Given this list of marker genes PRDM1, FOXP1, HDAC4, GALNT18, LSM8, OLFM1, ANKS1B, NDNF, HSP90B1, SH2B3, SP3, DDIT4 (DNA damage inducible transcript 4), FEZ2, MPZ, FOXO3, CYTIP, ANAPC10, DBT (NCBI Gene Id 1629), HMGCS1, FBXW7, PDS5B, KAT6A, TSPAN7, RERG, PTBP2, SLC37A3, FBXO8, SACS, FAM13C, RHOB, ACTA1, WDR43, LELP1, PAX6, LAMB1, HARBI1, ZNF772, SLC35G2, ADGRB3, GMFB, RBPJ, G3BP1, GRIK1, CDH12, PRKCE, TMEM143, CBX5, SANBR, STAM, INPP4A, HOOK1, USP40, SNX6, WBP1L, SOD2, NFIB, CDK17, RAB8B, NFIA, ANKRD40, USP42, ARMCX1, SDC2, MAEL, BRMS1L, RBSN, CRIM1, UBR5, PARP1, ELK4, ACSL3 (acyl-CoA synthetase long chain family member 3), RCN2, C18orf54, DENND5B, RASA1, CALML4 (NCBI Gene Id 91860), FOXO1, SREK1, MYBL1, TMEM178B, INHBB, RRAS2, IGF1R, GTPBP8, KPNA3, SEPTIN6, ATP7A, TBC1D12, ZKSCAN5, SLC7A8, F3, ASXL3, INPP5B, KPNA1, TBC1D17, MYO5B, SMAD1, RIBC1, LACC1, SORBS1, SIAH1, SPTLC2, LMO2, CSNK1A1L, FKBP5, SMIM15, SLC29A1, HLF, NUP210, TENT5A, TWF1, NOTCH2, ZBTB42, UBE2A, ADCY7, ATG7, SLC4A4, ARHGEF38, SLC8A1, RUBCNL, PDS5A, here is a description of the gene set: studied in species Homo sapiens Genes predicted to be targets of miRBase v22 microRNA hsa-miR-223-3p in miRDB v6.0 with MirTarget v4 prediction scores > 80 (high confidence targets). from publication Chen Y, Wang X (PMID 31504780) Human Gene Set: MIR223_3P